Given this list of marker genes MME, NECTIN1, TP63, IRF6, MSX1, SERPINC1, here is a description of the gene set: Human Gene Set: HP_PREGNANCY_EXPOSURE species: Homo sapiens Pregnancy exposure Exposure of pregnant women to toxins from any source, such as environmental toxins or chemicals, that may potentially cause problems such as miscarriage, preterm delivery, low birth weight, and, in some cases, developmental delays in infants.